The following is a description of a gene set: studied in species Homo sapiens Human Gene Set: GOBP_NEGATIVE_REGULATION_OF_MACROPHAGE_CHEMOTAXIS Any process that decreases the rate, frequency or extent of macrophage chemotaxis. Macrophage chemotaxis is the movement of a macrophage in response to an external stimulus., and this is the list of marker genes: C5, MMP28, STAP1, DDT, MIF, CYP19A1, SLAMF8